Given this list of marker genes Ccl8, Hapln1, Ndufaf7, Sptbn1, Tmem33, Fut8, Thap2, Pabpc4l, Rock2, Fbxo8, Klhl15, Drg2, B230219D22Rik, Ccdc59, Ghitm, Pcnx1, Ryr3, Reg1, Lin9, Etfa, Ccr3, Hnrnpa3, Hmcn1, Eif2ak4, Cadm2, Cnr1, Pde7a, Cntrob, Cept1, Ttl, Slc25a2, Rfx3, Septin9, Rhoj, Pnpla8, Ugt2b1, Dmrt1, Tuba4a, Ncoa7, Hsd3b6, Smad4, Cdc42se2, Arcn1, Bcl7b, Rnf38, Alg2, Sirt1, Zbed4, Ubfd1, Acad9, Rab10, Spats2l (NCBI Gene Id 98693), Macir, Hebp1, Zfp712, Sass6, Gabrb2, Pramel24, Tafa1 (NCBI Gene Id 320265), Lims1, Mbnl2, Chmp5, Mr1, Aif1l, Gart, Sp1, Lnx2, Tpbg, Tet1, Igf1, Dusp22, Onecut3, Peg12, Ankrd12, Myo5c (NCBI Gene Id 546146), Arhgap15, Cstpp1, Pcdhb18, Ttpal, Cpne8 (NCBI Gene Id 70271), Azi2, Rmdn3 (regulator of microtubule dynamics 3), Sprr2a3, Usp46, Spint4, Kcns3, Ufl1, Megf11, Fhip2a, Cyria, Plscr1, Slc8a1, Zbtb33, Abca8b, Nap1l1, Cilk1, Tox3, Ccnyl1, Plekhm3, Dtwd2, Atrn, Tut7, Pitpnm3, Wbp2, Abcb10 (NCBI Gene Id 97438), Pde12, Zbtb41, Tyr, Ccser1, Pla2g6, Frat1, Cmtr1, Tm9sf3, Hecw1, D5Ertd579e, Iqub, Mrc1, Phtf2 (NCBI Gene Id 97226), Fer1l5, Spag16, Pdia5, Abraxas2, Map3k2, Cdkn2aip, Pmel, Rpap1, Hs3st2 (NCBI Gene Id 195646), Zbtb44, Tfcp2l1, Ermp1, Evi5, Tob1, Sh3gl3, Zfp407, Aftph, Esf1, Jam3, Hycc1, Cap1, Sec62, Slc17a2, Mnt, Aasdhppt, Pdlim5, Fut4, Dennd6a, Actr6, Ywhab (tyrosine 3-monooxygenase/tryptophan 5-monooxygenase activation protein, beta polypeptide), Olfm3, Col9a3, Rrm2b, Pde10a, Xpo1, Cyp24a1, Tmem47, Grm5, Apba1, Phf3, Bach2, Stam2, Ube2j1, Parl, Zfyve16, Pros1, Traf7, Carnmt1, Wdr44, Hexd, Cisd2, Cwc27, Gm11992, Diaph2, B4galt6, Prkaa2, Trim33, Cox7b, Srsf3, Il2, Lypla1, Mgat3, Tmem43, Apaf1, Zfp644, Elmo1, Ap1s1, Mecp2, Sorbs2, Zmym2, Ybx3 (Y box protein 3), Mapk8, Nol4, Apoh, Klhl22 (kelch-like 22), Rfxap (NCBI Gene Id 320768), Reck, Stpg2, Ankib1, S2bpcox16, Phkg2, Nbea, Cdh9, Cdv3, Stxbp3, Snx11, Abcc4, Il3, Ang4, Creb1, Prkd3, Gpc4, Adamts5, Rps6kb1, Fa2h, Sema3a, Mios, Myrip, Zkscan8, Ube2g1, Fut9, Gja1, Tsc22d2 (NCBI Gene Id 74514), Csrp2, Slc12a1, Kynu, Insyn2a, Csad, Dennd5b, Arpp19, Rsbn1, Cox16, Relch, Bltp3b, Arpp21, Srp19, Timm8a1, Hypk, Cdhr3, En1, Tmed7, 9530068E07Rik, Gucy1a2, Atp8a1, Fbxl17, Elf2, Etfrf1, Sult1d1, Rer1, Rbbp4, Naaladl2 (N-acetylated alpha-linked acidic dipeptidase-like 2), Gpr101, Vps4b, Lancl3, Erbin, Sult1c2, Apbb2, Crym, Fat3, Xpot, Mapk9, Pmfbp1, Dst, Tex9, Tmod2, Dusp16, Jchain, Prkaa1, Pdzk1ip1, Homer1, here is a description of the gene set: Mouse Gene Set: MIR_205_3P species: Mus musculus from publication Chen Y, Wang X (PMID 31504780) Genes predicted to be targets of miRBase v22 microRNA mmu_miR_205_3p in miRDB v6.0 with MirTarget v4 prediction scores > 80 (high confidence targets).